The following is a description of a gene set: studied in species Mus musculus electronically inferred by orthology from the curated human pathway part of: N-glycan trimming and elongation in the cis-Golgi Reactome Pathway: Progressive trimming of alpha-1,2-linked mannose residues from Man9/8/7GlcNAc2 to produce Man5GlcNAc2 This event has been computationally inferred from an event that has been demonstrated in another species.<p>The inference is based on the homology mapping from PANTHER. Briefly, reactions for which all involved PhysicalEntities (in input, output and catalyst) have a mapped orthologue/paralogue (for complexes at least 75% of components must have a mapping) are inferred to the other species., and this is the list of marker genes: Man1a, Man1c1